Given this list of marker genes Gtpbp2, Syngr4 (NCBI Gene Id 80661), Chfr, Actg1, Psd, Slc39a1, Rgs8, Traf3, Clip3, Ptprf, Trabd2b, Dpysl5, Rprm, Chmp7, Epn2, Stra6, Ptpmt1, Dnajc3, Iqsec2, Ilf2, Dnmt3a, Sirpa, Sdf4, Nkain3, Ank3, Ceacam15, Tfe3, Gpr137, Trpv4, Atp13a3, Clpb, Cadm1, here is a description of the gene set: from publication Chen Y, Wang X (PMID 31504780) species: Mus musculus Mouse Gene Set: MIR_665_5P Genes predicted to be targets of miRBase v22 microRNA mmu_miR_665_5p in miRDB v6.0 with MirTarget v4 prediction scores > 80 (high confidence targets).